The following is a description of a gene set: studied in species Mus musculus Mouse Gene Set: GOCC_ROUGH_ENDOPLASMIC_RETICULUM_LUMEN The volume enclosed by the membranes of the rough endoplasmic reticulum., and this is the list of marker genes: Resp18, Lyz2, Lrpap1, Vtn, Edn1, Chil3, Lyz1